The following is a description of a gene set: studied in species Homo sapiens Human Gene Set: GOBP_REGULATION_OF_T_CELL_DIFFERENTIATION_IN_THYMUS Any process that modulates the frequency, rate or extent of T cell differentiation in the thymus., and this is the list of marker genes: SOS2, CLEC4G, CDKN2A, SHH, ADA, SOS1, FOXJ1, ERBB2, TESPA1, TMEM131L, RAG2, ADAM8, ZC3H8, GLI2, ZEB1, FOXN1, IL2RG, TOX, VNN1, PTPN2, BMP4, IL7R, EGR3, SOD1, CLPTM1, CAMK4, RASGRP1, IHH